The following is a description of a gene set: A heterochromatin formation-based gene silencing process mediated by a regulatory non-coding RNA molecule that occur before the beginning of trancription. Mouse Gene Set: GOBP_REGULATORY_NCRNA_MEDIATED_HETEROCHROMATIN_FORMATION studied in species Mus musculus, and this is the list of marker genes: Spocd1, Piwil2, Tdrd5, Ezh2, Hnrnpu, Gm38999, Tdrd12, Tdrd9, Hotair, Ddx4, Nrde2, Tex15, Mael, Piwil4, Dnmt3b, Spin1, Arb2a, Piwil1, Fkbp6, Tdrd1, Airn, Dnmt3a, Mov10l1, Znfx1, Dnmt3l, Hnrnpk